Given this list of marker genes Brd4, Cdk13 (cyclin dependent kinase 13), Acvr2b, Stradb, Acvr2a, Ccnc, Polr3g, Gmppb, Prkab2, Ikbkg, Pfkl, Prps1l1, Tada3, Ccnk, Polr2f, Polr1b, Tex24, Pycard, Gtf2h1, Med12, Pard3, Polr3c, Ccni, Pcna, Polr2l, Dna2, Tgfbr2, Ceacam2, Erc1, Skic8, Cdk2, Csnk2a1, Polr2d, Psmc5, Cab39, Akap14, Pold4, Pola2 (polymerase (DNA directed), alpha 2), Ccnt2, Polr3e, Cks1brt, C9orf72, Trim40, Polr2c, Ccnf, Acvr1b, Gtf2b, Taf4, Polr1a, Cdkn1a, Kat2a, Insrr, Primpol, Cdk11b, Taf7, Rpap1, Prkag1, Ccna2, Pfkfb1, Znfx1, Ercc2, Paf1, Prps1, Pard6a, Pik3r5, Becn2, Polr3gl, Papss1, Pik3ca, Irs1, Mlst8, Polg, Gtf2h5, Rb1, Polr2e, Gtf2a1l, Pik3cb, Prim1, Polr2i, Atxn7l3, Csnk2b, Rtf1, Taf6l, Phkg2, Tgfbr1, Polg2, Ccnl1, Prkx, Cks1b, Ugt3a1, Prkab1 (protein kinase, AMP-activated, beta 1 non-catalytic subunit), Las1l, Pkm, Ccne2, Polr3a, Cdk12, Prkag2, Ccnb2, Gmppa, Strada, Mapkap1, Prpsap1, Cdkn2d, Pex2, Cdk5, Mnat1, Insr, Tuft1, Ulk1, Ugt3a2, Phka2, Chuk, Acvr1c, Prkci, Cdk6, Prps1l3, Gtf2e2, Taf5, Gtf2h4 (NCBI Gene Id 14885), Crcp (NCBI Gene Id 12909), Ccny, Cdk9, Polrmt, Gtf2a2, Cnppd1, Alg13, Taf4b, Polr3h, Pklr, Pik3r6 (phosphoinositide-3-kinase regulatory subunit 5), Zbtb7a (zinc finger and BTB domain containing 7a), Taf1, Atg13, Bccip, Ccnl2, Polr2k, Polr2b, Ccnb3 (NCBI Gene Id 209091), Pik3r2, Xrcc5 (X-ray repair complementing defective repair in Chinese hamster cells 5), Cdk5r2, Dbf4, Taf6, Prkar2a, Pole2, Polr2h, Prkar1a, Gtf2e1, Pole3, Cdk14, Pola1, Ccnjl, Cdk8, Leo1, Cks2, Ccnq, Myzap, Ccnd2, Tert, Phka1, Cdk7, Prim2, Prkar1b, Nek10, Ccnd3, Polr1e, Rev3l, Ccng1, Atxn7 (NCBI Gene Id 78432), Cdk16, Gtf2a1, Wdr41, Smcr8, Ccnb1-ps, Ccnh, Prkaa2, Prpsap2, Pfkm, Pfkp, Pik3r3, Gtf2f2, Ccnj, Atg101, Ercc3 (NCBI Gene Id 13872), Prkag3, Taf2, Pik3c3, Dapk1, Ccng2, Pole4, Polr1h, Snw1, Ctr9, Ceacam1, Taf7l, Phkg1, Gtf2f1, Gtf2h3, Acvr1, Tcea1, Cdk10, Polr3k, Cdc73, Tbpl1, Taf3, Polr1d, Ccnd1, Polr3d, Prps2, Polr2g, Usp22, Pold3, Vac14, Alg14, Prkaca, Gnptg, Pold2, Polr2a, Cdk1, Csnk2a2, Polr3f, Pik3r4, Taf9b, Taf11, Trrap, Taf13, Taf9, Cdk3, Polr1c (NCBI Gene Id 20016), Rb1cc1, Polr1g, Pole, Gtf2h2, Atg14, Xrcc6, Pik3cd, Taf10, Ikbkb, Tbp, Taf8, Supt3, Med13, Becn1, Pik3cg, Tbc1d5, Ccna1, Prkar2b, Ccne1, Ext2, Sesn2, Pold1, Rictor, Map3k5, Ccnt1, Taf5l, Cdk5r1, Uvrag, Ccno, Pik3r1, Prkacb, Nrbf2, Taf12, Mtor, Polr2j, Igf1r (NCBI Gene Id 77773), Stk11, Phkb, Mad2l2, Polr1f, Cdk4, Eny2, Ccnb1, Prkaa1, Prkdc, Polr2m, Polr3b, here is a description of the gene set: Mouse Gene Set: GOCC_TRANSFERASE_COMPLEX_TRANSFERRING_PHOSPHORUS_CONTAINING_GROUPS species: Mus musculus A transferase complex capable of catalysis of the transfer of a phosphorus-containing group from one compound (donor) to another (acceptor).